The following is a description of a gene set: Food allergy Primary food allergies primarily occur as a result (most likely) of gastrointestinal sensitization to predominantly stable food allergens (glycoproteins). A secondary food allergy develops after primary sensitization to airborne allergens (e. g., pollen allergens) with subsequent reactions (due to cross-reactivity) to structurally related often labile allergens in (plant) foods. Human Gene Set: HP_FOOD_ALLERGY studied in species Homo sapiens, and this is the list of marker genes: RBM8A, IGHG2, CAMK2B, SPINK5, IGKC, CARD11, IL6ST, ABCC9, DOCK8 (NCBI Gene Id 81704), SLC27A4, STAT6, SOX6, FOXP3, SLC19A1, PGM3, JAK1, FOCAD, POLD3 (NCBI Gene Id 10714), DSG1, SPTBN1